Given this list of marker genes Crk, Kidins220, Ngf, here is a description of the gene set: part of: Prolonged ERK activation events electronically inferred by orthology from the curated human pathway species: Mus musculus Reactome Pathway: ARMS-mediated activation This event has been computationally inferred from an event that has been demonstrated in another species.<p>The inference is based on the homology mapping from PANTHER. Briefly, reactions for which all involved PhysicalEntities (in input, output and catalyst) have a mapped orthologue/paralogue (for complexes at least 75% of components must have a mapping) are inferred to the other species.